Given this list of marker genes POLR2F, SARNP, SRSF11 (serine and arginine rich splicing factor 11), RBM5, SNRPA, RBM17, HNRNPU, PCBP2, PPP1CB, THOC2, SF3B3, RBBP6, SRRT, YBX1, SNRPB2, RBM39, SRSF12, ZC3H11A, DHX15, PCF11, U2SURP, DDX39B, SUGP1 (SURP and G-patch domain containing 1), GTF2F1, SRSF4, SRSF10, POLR2I, HNRNPA3, PPP1R8, GTF2F2, POLR2H, DHX9, THOC5, HNRNPL, SLU7, CHERP, PPP1R10, PPP1CA, UPF3B, SRSF6, HNRNPC, PHF5A, DNAJC8, DDX39A, SF3B1, POLR2A, DDX46, POLR2L, SF3B4, SNRPD2, HNRNPD, MAGOH, UBA52, SRSF7, FYTTD1, SF3B6, CLP1, XRN2, SMNDC1, CPSF2, FUS, ALYREF, TRA2B, HNRNPH1, CSTF2T, SNRPF, SNRPC, POLR2J, RBM8A, UBC, HNRNPH2, DDX42, HNRNPK, CPSF3, HTATSF1, POLR2E, WDR33, CSTF1, TUT1, SRSF2, SNRPD3, SNRPG, PUF60 (NCBI Gene Id 22827, poly(U) binding splicing factor 60), PCBP1, CSTF2, MAGOHB, THOC7, POLR2D, DDX5, SRRM2, SRSF9, POLR2B, SRSF3, LUZP4, SNRNP70, EIF4A3, RBM10, NCBP1, PRPF40A, POLR2K, CDC40, PAPOLA, SNRPB, SF3B2, HNRNPA2B1, CPSF7, CPSF6, HNRNPF, SRSF1, THOC6, SF3A2, HNRNPA1, RPS27A, SNRPA1, CCAR1, POLR2C, U2AF1, SF3B5 (NCBI Gene Id 83443), RBMX (RNA binding motif protein X-linked), POLDIP3, PABPN1, HNRNPM, RNPS1, CASC3, FIP1L1, POLR2G, THOC3, SYMPK, SRRM1, DHX38, SNRPN, CHTOP (NCBI Gene Id 91678), UBB, NCBP2, SRSF8, SNRPE, U2AF1L4, CPSF1, U2AF2, CSTF3 (NCBI Gene Id 1479), CPSF4, HNRNPR, SNRPD1, NUDT21, THOC1, SF3A3, TCERG1, PAPOLG, SRSF5, RBM25, PTBP1, SF3A1, here is a description of the gene set: studied in species Homo sapiens The 3' ends of eukaryotic mRNAs are generated by posttranscriptional processing of an extended primary transcript. For almost all RNAs, 3'-end processing consists of two steps: (i) the mRNA is first cleaved at a particular phosphodiester bond downstream of the coding sequence, (ii) the upstream fragment then receives a poly(A) tail of approximately 250 adenylate residues, whereas the downstream fragment is degraded. The two partial reactions are coupled so that reaction intermediates are usually undetectable. While 3' processing can be studied as an isolated event <i>in vitro</i>, it appears to be connected to transcription, splicing, and transcription termination <i>in vivo</i>.<p>The only known exception to the rule of cleavage followed by polyadenylation are the major histone mRNAs, which are cleaved but not polyadenylated. part of: Processing of Capped Intron-Containing Pre-mRNA Reactome Pathway: mRNA 3'-end processing